The following is a description of a gene set: Human Gene Set: ROVERSI_GLIOMA_COPY_NUMBER_UP from publication Roversi G, Pfundt R, Moroni RF, Magnani I, van Reijmersdal S, Pollo B, Straatman H, Larizza L, Schoenmakers EF (PMID 16247447) Identification of genetic copy number changes in glial tumors is of importance in the context of improved/refined diagnostic, prognostic procedures and therapeutic decision-making. In order to detect recurrent genomic copy number changes that might play a role in glioma pathogenesis and/or progression, we characterized 25 primary glioma cell lines including 15 non glioblastoma (non GBM) (I-III WHO grade) and 10 GBM (IV WHO grade), by array comparative genomic hybridization, using a DNA microarray comprising approx. 3500 BACs covering the entire genome with a 1 Mb resolution and additional 800 BACs covering chromosome 19 at tiling path resolution. Combined evaluation by single clone and whole chromosome analysis plus 'moving average (MA) approach' enabled us to confirm most of the genetic abnormalities previously identified to be associated with glioma progression, including +1q32, +7, -10, -22q, PTEN and p16 loss, and to disclose new small genomic regions, some correlating with grade malignancy. Grade I-III gliomas exclusively showed losses at 3p26 (53%), 4q13-21 (33%) and 7p15-p21 (26%), whereas only GBMs exhibited 4p16.1 losses (40%). Other recurrent imbalances, such as losses at 4p15, 5q22-q23, 6p23-25, 12p13 and gains at 11p11-q13, were shared by different glioma grades. Three intervals with peak of loss could be further refined for chromosome 10 by our MA approach. Data analysis of full-coverage chromosome 19 highlighted two main regions of copy number gain, never described before in gliomas, at 19p13.11 and 19q13.13-13.2. The well-known 19q13.3 loss of heterozygosity area in gliomas was not frequently affected in our cell lines. Genomic hotspot detection facilitated the identification of small intervals resulting in positional candidate genes such as PRDM2 (1p36.21), LRP1B (2q22.3), ADARB2 (10p15.3), BCCIP (10q26.2) and ING1 (13q34) for losses and ECT2 (3q26.3), MDK, DDB2, IG20 (11p11.2) for gains. These data increase our current knowledge about cryptic genetic changes in gliomas and may facilitate the further identification of novel genetic elements, which may provide us with molecular tools for the improved diagnostics and therapeutic decision-making in these tumors. Genes in the most frequently gained loci in a panel of glioma cell lines. studied in species Homo sapiens, and this is the list of marker genes: KMT2C, ECT2, SUGT1, MZF1, PSMC3, MADD, GALNT7, CNMD, NR1H3, ARHGAP1, SPATA16, EYS, NECTIN2, SLC27A5, GALNT5, CALCR, CEACAM19, PRKAG2, ERCC2, RELB, ZNF132, CHRM4, GALNT9, SLC26A5, DDB2, SYT13, PIK3CG, ZNF296, CHST1, LRP4, CREB3L1, PTPRJ, TRIM28, TSPAN13, XRCC2, MBD3L1 (methyl-CpG binding domain protein 3 like 1), ABCF2, MARK4, CLPTM1, NAMPT, CKM, PEX16, TOMM40, KLC3, POLR1G, ELMO1, ZNF408, PMS2P2, UBE2M, BCAM, RHEB, FOSB, GALNT11, ZNF324, KMT2E, CKAP5, MYBPC3, AHR, GALNT8, ZNF584, GEMIN7, DGKZ, NSUN5P1 (NSUN5 pseudogene 1), FOLH1, PACSIN3, NLGN1, BCL3, NUB1, ORC5, F2, EXOC3L2, SLC7A11, PTPRN2, ERCC1, SPI1, MAPK8IP1, APOC2, ZBTB45, APOC4, SYPL1, VIPR2, RELN, SLC35C1, PHF21A, APOE, SMARCD3, APOC1, GALNT6, MDK, DPF1, CRY2, GALNT10, DGKI, OR2Z1, CLASRP, CBLC, ACP2, SIPA1L3 (NCBI Gene Id 23094), PPP1R13L, PCDH18